The following is a description of a gene set: Paroxysmal bursts of laughter species: Homo sapiens Human Gene Set: HP_PAROXYSMAL_BURSTS_OF_LAUGHTER, and this is the list of marker genes: GRIK2, UBE3A, HSD17B10, TTI1, MBD5, TELO2 (telomere maintenance 2, NCBI Gene Id 9894), WDR4, ATRX, CDKL5, GLI3, NTNG2, SNRPN